The following is a description of a gene set: Human Gene Set: WP_GLUCURONIDATION Glucuronidation species: Homo sapiens, and this is the list of marker genes: UGT1A9, PGM2, UGT2A3, PGM1, UGT1A6, PGM3, UGT2B4, UGT1A4, PGM5, UGT1A8, UGT2A1, UGT2B15, UGT1A1, UGDH, UGT2B10, UGT2B17, UGT1A7, UGP2, UGT2B7, UGT1A10, UGT1A5, UGT1A3, HK1, UGT2B28, UGT2A2, UGT2B11